The following is a description of a gene set: Any deviation of the concentration of one or more proteins in the urine. Human Gene Set: HP_ABNORMAL_URINE_PROTEIN_LEVEL studied in species Homo sapiens Abnormal urine protein level, and this is the list of marker genes: OCRL, NUP93, CFI, COL4A3, KCNJ11, KIF1B, MT-ND1, HNF4A, LRP2, UNC45A, CUBN, ABCC8, DLST, SMARCAL1, MTX2, SLC37A4, PLCE1, KCNE5, NDUFAF6 (NCBI Gene Id 137682), MT-CO2, FH, OSGEP (O-sialoglycoprotein endopeptidase), SPP1, IGHG1, DKC1, MT-TH, SEC61A1, SDHC, WDR73, HLA-DPB1, VPS33A, EMP2, PKD1, NUP107, METTL27, NIPBL, MYO1E, BLK, GCK, PDCD1, KIRREL1, SLC2A9, SLC25A11, INS, STX1A, SH2B1, FCGR3B, DNASE1, PSTPIP1, SARS2, SLC22A12, MT-ND6, KANK2, COQ8B, NOS3, ZAP70, MIA3, WT1, TLR7, ALG9, MT-CO1, VHL, SLC12A3 (solute carrier family 12 member 3), FCGR2B, NOTCH2, SLC34A1, VIPAS39, UMOD, MT-CO3, SPRY2, HNF1B, FKBP6, ERCC8, FAN1, SURF1, TRIM8, CLDN16, FLT1, MT-TF, MAX, MT-TQ, CLCN5, ACP5, TNIP1, ETS1, HLA-DPA1, LMNB2, THBD, C4B, LMX1B, NOS1AP, MEFV, HMOX1, KIAA0319L, G6PC1, COL4A4, LAMB2, APOL1, IER3IP1, GATA3, MYH9, ITGA3, CD46, LCAT, PRTN3, DPH1, SLC35A1, NPHS2, COQ2, GANAB, RFC2, MAFB (MAF bZIP transcription factor B), GBA1, PRDX1, NPHS1, SAA1, ALG5, MT-TS2, CFH, ANLN, EHHADH, GATM, TPRKB, VPS37D, GALT, PAX2, PYGL, ARHGAP24, ADAMTS13, FN1 (NCBI Gene Id 2335), PRODH, NF1, GLA, TREX1, IRF5, MAF, PKD2, WDR4, ADA2, PMM2, NCF1, MT-TL1, MT-ND5, TBL2, JAZF1, NUP160, NEU1, PXK, SLC7A7, PIGA, DAAM2, APOE, TRPC6, ATP7B, STAT2, STAT3, LPIN2, DNAJB11, PEX1, CTLA4, SDHAF2, SLC2A2, COL6A1, GON7, BUD23 (NCBI Gene Id 84118), ERCC4, ELN, MT-TN, DGKE, CTNS, MT-ND4, NUP133, OFD1, CRB2, TP53RK, CFB (complement factor B), SDHA, CR2, SDHB, PDX1, LYZ, NUP205, ANKFY1, C1GALT1C1, AMN, DNMT3A, DNASE1L3, NPHP3, STAT4, YRDC, CLCNKB, COA8, MMACHC, GTF2IRD1, APOA1, COL4A5, GAPVD1, PUS3, BICC1, MECP2, EXT2, LAGE3, ARHGDIA, DDOST, PTPRO, ACSL4, INF2, TBC1D8B, APRT, TNFAIP3, IFT140, PTPN22, ERCC6, GSN, RET, C3, CORIN, EPAS1, SCARB2 (scavenger receptor class B member 2), WDR19, PBX1, FOXC2, ITGA8, PDSS2, CD81, MED12, CD2AP, VPS50, NUP37, MAGI2, IRAK1, LMNA, BANK1, EIF4H, BAZ1B, SAT1, MDH2, COQ6 (coenzyme Q6, monooxygenase), HELLPAR, C4A, DNASE2, IL10, CLIP2, SDHD, LIMK1, TNFSF4, STOX1, ITGAM, ACTN4, TMEM270, COL4A6, HLA-DRB1, AMMECR1, SNAP29, UBE2L3, KARS1, SGPL1, NUP85, RNU7-1, GTF2IRD2, TMEM127, MT-TW, VPS33B, FGA, REN, GTF2I, DNAJC30, IFT172